Given this list of marker genes SOSTDC1, BMPR1B, BMPR2, ACVRL1, HJV, LTBP4, AMHR2, ACVR1, TGFBR3, BMPR1A, ACVR1C, ACVR2A, LTBP1, TGFBR1, TGFBR3L, TGFBR2, ACVR2B, ACVR1B, here is a description of the gene set: Combining with a signal and transmitting the signal from one side of the membrane to the other to initiate a change in cell activity by catalysis of the reaction: ATP protein serine = ADP + protein serine phosphate, and ATP + protein threonine = ADP + protein threonine phosphate. studied in species Homo sapiens Human Gene Set: GOMF_TRANSMEMBRANE_RECEPTOR_PROTEIN_SERINE_THREONINE_KINASE_ACTIVITY